The following is a description of a gene set: Binding to a neuregulin, a member of the EGF family of growth factors. Mouse Gene Set: GOMF_NEUREGULIN_BINDING studied in species Mus musculus, and this is the list of marker genes: Itgb4, Itgb3, Erbb4, Itgav, Itga6, Erbb3